Given this list of marker genes IL2, IGFBP4, ATP6V1A, TMEM141, CPD (carboxypeptidase D), CA1, S100A9, GPAT4, TUFM, FLT3, GNG12, SPP1, EPAS1, EPO, WLS, RASA4, SOX7, SLC25A53, LY6D, CTNND2, ZIC1, ACKR3, ACSL1, PRKCA (NCBI Gene Id 5578), MAP7D1, UGP2, PLA2G2C, ZNFX1, GPX1, NME4, BDKRB1, CPQ, THBS1, ITM2C, PDLIM1 (PDZ and LIM domain 1), TNFRSF1A, SLC6A4, CMBL (NCBI Gene Id 134147), PRDX1, AKR1B15, COL14A1, IL18, PALD1, PHLDA2, AURKA, ABCG2, TNNI1, TGFBI, NCOA4, ARRB1, CFP (complement factor properdin), DBNDD2, S100A8, FLOT1, COL19A1, TXK, OXSM, SLC8A1, KRT20, ADRA1A, PSAP, KHK, NRSN1, PTER, CD14, RGL1, CKB, SLC32A1 (solute carrier family 32 member 1), CASP3, P4HA1, TNFRSF21, COMT, AHRR, ST3GAL4, ABCC3, INTS7, FECH, TYMS (NCBI Gene Id 7298), BCL2L13, SBF2, SLC29A1, GPD1, C19orf73, PINK1, CHMP4B, CORO1C, HMOX1 (heme oxygenase 1), DHCR24, PEA15, DPYSL3, GNRHR, GALNT3, ATP1B3, PPARG, TRAF1 (NCBI Gene Id 7185), GKAP1, ELK4, VNN2, ATP1B1, NBN (nibrin), ICOS, LEPROT, RAB3IL1, TSPAN4, CLEC4A, HP, ENAM, NAV1, GATA3, ARHGAP39, YWHAE, GOLIM4, CYSTM1, PLXNB2, HNRNPLL, AKR1A1, ZAP70, AXL, PTGS1 (prostaglandin-endoperoxide synthase 1), DAPK2, IDH2, MSX2, COX5A, ADAM11, NEUROG1, HSD3B7, ITM2B, SOCS2, AQP8, H3-5, S100A4, PRSS58, PAX9, MATN2, SC5D, SPIC, B3GALT6, DMTN, HOXC6, IL1A, CCL2, TYRO3 (TYRO3 protein tyrosine kinase), TULP1, FHDC1, AGAP3, CELF4, DAGLB, AATK, IRF6, KLF17, DNAJB9, BDNF, ENPP1, SURF4, GBP7, TENM4, MGST1, PAM, ATP6V1E1, PAQR7, TNFRSF9, NFIX, CCL19, LAP3, SERPINB6, CADM1, PLAC9, UGCG, HFE, LPL, POSTN, RNPEP, ITK, GATM, RIT1, GINM1, TRAF2, SLC10A6, YWHAG, UBD, GABBR1, MAPK13, ATP6V1G1, ACTN1, NES, SLCO5A1, CTSB, TH, GLRX, CTDP1, S100A5, HBB, SLC12A7, ENPEP, DYNLL2, P4HA2, CD160, SLC44A4, PTPRO, VCAM1, here is a description of the gene set: Bruton's tyrosine kinase (Btk) is important for B lymphocyte development. To identify genes that are differentially expressed in primary B cells lacking functional Btk, splenocytes from X-linked immunodeficiency (Xid), Btk knockout (KO) and immunocompetent CBA mice, were used in microarrays containing more than genes and expressed sequence tags (ESTs). We found 4515 transcripts expressed in duplicate experiments in all three strains. Out of these, 38 were differentially expressed genes (21 up-regulated >2 fold and 17 down-regulated <-2 fold) between CBA and Btk defective mice. Ten out of these genes were selected and quantitative Real-Time PCR was conducted for validation and further investigation. Real-Time experiments correlated nicely with the microarray data. No definitive phenotypic difference has previously been reported between Xid and Btk KO mice. We found genes, whose expression differed (>2 fold) between the two strains. Moreover, when the genes, which differed between immunocompetent CBA and Btk defective mice were ranked according to fold-increase, the levels in Btk KO mice were significantly more altered. This suggests that the defect in Btk KO mice is more severe and demonstrates that the mutant Btk protein in Xid mice does not generally function as dominant negative form. Human Gene Set: GSE2826_WT_VS_BTK_KO_BCELL_DN from publication Lindvall JM, Blomberg KE, Berglöf A, Yang Q, Smith CI, Islam TC (PMID 15214046) Genes down-regulated in comparison of primary splenic B cells from wild type mice versus those from BTK knockout mice. species: Homo sapiens